The following is a description of a gene set: studied in species Homo sapiens The appearance of IP-10 due to biosynthesis or secretion following a cellular stimulus, resulting in an increase in its intracellular or extracellular levels. Human Gene Set: GOBP_IP_10_PRODUCTION, and this is the list of marker genes: OAS3, OAS1, LILRB4 (leukocyte immunoglobulin like receptor B4), MAVS, MIR34A